The following is a description of a gene set: species: Homo sapiens Human Gene Set: LAKE_ADULT_KIDNEY_C1_EPITHELIAL_CELLS_UNASSIGNED from publication Lake BB, Chen S, Hoshi M, Plongthongkum N, Salamon D, Knoten A, Vijayan A, Venkatesh R, Kim EH, Gao D, Gaut J, Zhang K, Jain S (PMID 31249312), and this is the list of marker genes: GPX3, CALD1, DLGAP1, NPAS3, SPATA22, RAPGEF2, TRABD2B, LRP2, MAST4, PTPRD, CPQ, CMC2, LRMDA, PLCL1, NHS, CSMD2, TAOK1, TLN2, NRG3, MACROD2, ZBTB16, PAMR1, FARP1, SLC5A12, SLC13A3, MEIS2, PTH1R, PBX1, GMDS-DT, EPB41L3